Given this list of marker genes SRR, NOL11, RBM15B, COX17 (cytochrome c oxidase copper chaperone COX17), UQCRH, ARL4A, CBR1, ACAT1, NHP2, DNAAF2, RNPS1, SLC39A7, NAPG, SKA1, APOL6, CTNNAL1, POLDIP2, RMDN1, ERCC6L, RPL26L1, ACAA2, TIMM8B, MOB4, MNAT1, GEMIN2, USP18, MTIF2, KIF18A, MRPS18A, SOD2, ESRRA, DDRGK1, PSMC6, GOT2, COX7B, PWP1, NFIL3, PFN1, NELFE, ENOPH1, STX18, CLPP, SUV39H1, ANAPC10, MAPKAPK3, XRCC6, NUS1P3, TSR1, BLVRA, PAXIP1, LY6E, EMC6, GNG5, UQCRC1, SMC4, AIRIM, HMGA1, RAC1, PRPF19, UBR7, DCAF17, CBX6, SRBD1, KIFC1, MAGOH, COX8A, APOL1 (NCBI Gene Id 8542), RFC2, OLA1 (Obg like ATPase 1), GTF2H4, PML, MCMBP, TGS1, SH2B3, CDC23, CHUK, XPO1, SRPRA, RPP30 (NCBI Gene Id 283012), POLR2E, NIT2, CCDC85B, GCN1, GOLT1B, MRPS12 (mitochondrial ribosomal protein S12), ATF6, PPP6C, NOC3L, RUSC1, MRPS33, SNRNP27, OAS3, UTP3, SLC25A44, VBP1, MIF, EHD4, METTL1, IFI27, GPI, PANX1, PGAP2, CYC1, UBE2L6, GNL3, MRPS2, UBAP2 (ubiquitin associated protein 2), MRPL23, PMM2, TARDBP, ELP4, DHRS11, CISD1, TMEM165, MIS18A, CALU, PLAA, PPAT, SP110 (SP110 nuclear body protein), CNOT9, TMEM11, PSMD5, AURKAIP1, PSMB8, YWHAE, PPAN, MRPL52, MRPL40, ALG3, DHODH, CSNK2A1 (NCBI Gene Id 1457), TIMM8A, FASTKD2, DNTTIP2, TACO1, DRAP1, CPOX, ERI3 (ERI1 exoribonuclease family member 3), RBM7, TRIT1, PDHA1, UBE2L3, MAPRE1, FASTKD1, PPM1G, BNIP1, BMAL2, HCFC1, PSMD3, MED8, PSME2, G3BP1, INTS12, PSME3, INPP4B, PRIM1, ISG15, BHLHE40, ECHDC1, FASTKD3, DNPEP, ABCF1, NDUFS6, ATG101, SOCS1, SF3B4, EIF3A, NAT10, LSM4, SENP3, EIPR1, NCLN, TRAFD1, EBP, TRIB3, UBE2D3, GADD45GIP1, PSMG1, ECD, USP10, POP4, MRPL11, SLC19A1, RAD23A, XPO4, STAMBP, SKIC8, DYNC1LI1, MRPL16, TRIM21, ERAL1, RFWD3, CLPB, MX1 (NCBI Gene Id 4599), STEAP1, PMPCA, LYRM4, MRPS27, IFITM1, PFAS, here is a description of the gene set: Genes up-regulated in CD11b Tumor from BALBc mouse versus CD11b Tumor from C57BL6 mouse. Human Gene Set: GSE21927_BALBC_VS_C57BL6_MONOCYTE_TUMOR_UP Tumor growth is associated with a profound alteration of myelopoiesis, leading to recruitment of immunosuppressive cells known as myeloid-derived suppressor cells (MDSCs). Analyzing the cytokines affecting myelo-monocytic differentiation produced by various experimental tumors, we found that GM-CSF, G-CSF, and IL-6 allowed a rapid generation of MDSCs from precursors present in mouse and human bone marrow (BM). BM-MDSCs induced by GM-CSF+IL-6 possessed the highest tolerogenic activity, as revealed by the ability to impair the priming of IFN- -producing CD8+ T cells upon in vivo adoptive transfer. Moreover, adoptive transfer of syngeneic, GM-CSF+IL-6-conditioned MDSCs to diabetic mice transplanted with allogeneic pancreatic islets resulted in long term acceptance of the allograft and correction of the diabetic status. Cytokines inducing MDSCs acted on a common molecular pathway. Immunoregulatory activity of both tumor-induced and BM-derived MDSCs was entirely dependent on C/EBP transcription factor, a key component of the emergency myelopoiesis triggered by stress and inflammation. Adoptive transfer of tumor antigen-specific CD8+ T lymphocytes resulted in therapy of established tumors only in mice lacking C/EBP in myeloid compartment. These data unveil another link between inflammation and cancer and identify a novel molecular target to control tumor-induced immune suppression. We used gene expression analysis to identify those factors, secreted by tumor-infiltrating MDSC, which could drive emathopoiesis. Moreover we compare gene expression profile of tumor-induced MDSC, obtained from either the spleen and the tumor infiltrate of tumor bearing mice, and in vitro bone marrow-derived MDSC. from publication Marigo I, Bosio E, Solito S, Mesa C, Fernandez A, Dolcetti L, Ugel S, Sonda N, Bicciato S, Falisi E, Calabrese F, Basso G, Zanovello P, Cozzi E, Mandruzzato S, Bronte V (PMID 20605485) species: Homo sapiens